The following is a description of a gene set: studied in species Homo sapiens Human Gene Set: GOBP_SOMATIC_STEM_CELL_POPULATION_MAINTENANCE Any process by which an organism retains a population of somatic stem cells, undifferentiated cells in the embryo or adult which can undergo unlimited division and give rise to cell types of the body other than those of the germ-line., and this is the list of marker genes: SFRP1, WNT7A, ZHX2, PAX2, KLF4, BMP7, NR2E1, MED17, MED28, MED30, CUL4A, TP63, LIG4, SIX2, FGF4, SOX9, ASCL2, BCL9, LRP5, LBH, MED12, VANGL2, GATA2, LIF (NCBI Gene Id 3976), SALL4, WNT9B, POU5F1, HMGA2, ESRRB, MED21, SOX4, SKI, LDB2, NODAL, SMO, BRAF, SPI1, YAP1, STAT3, TBX1, MED27, RAF1, MED14, FGF10, NIPBL, HNF1B, MED6, TAF6L, BMPR1A, PAX8, MED10, CDX2, NR5A2, KLF10 (KLF transcription factor 10), MYC, HES1, BCL9L, SMC1A (structural maintenance of chromosomes 1A), REST, NANOG, NKAP, MED15, SOX2, TAF5L, NOG, KIT, MED24 (NCBI Gene Id 9862), MED7, MIR145, TAL1, ZFP36L2 (ZFP36 ring finger protein like 2), ELF5, RIF1, VPS72, RBPJ, CDKN2A (NCBI Gene Id 1029), LDB1, TFAP2C